Given this list of marker genes POTEE, ACTN2, DBNL (NCBI Gene Id 28988), ACTB, INA, ACTL8, POTEI, POTEF, CPNE6, NOS1AP, NEFH, MYH10, POTEJ (POTE ankyrin domain family member J), WASF2, SH3GL2, ACTBL2 (actin beta like 2), RAC3 (NCBI Gene Id 5881), FARP1, NEFL, KIF2C, POTEKP, ENAH, ACTG1, SRCIN1, EZR, here is a description of the gene set: Human Gene Set: GOBP_POSTSYNAPTIC_CYTOSKELETON_ORGANIZATION A process that is carried out at the cellular level which results in the assembly, arrangement of constituent parts, or disassembly of cytoskeletal structures comprising cytoskeletal filaments and their associated proteins in the postsynaptic cytoskeleton. studied in species Homo sapiens